The following is a description of a gene set: Down-regulated genes in pediatric adrenocortical tumors (ACT) compared to the normal tissue. Pediatric adrenocortical tumors (ACT) are rare and often fatal malignancies; little is known regarding their etiology and biology. To provide additional insight into the nature of ACT, we determined the gene expression profiles of 24 pediatric tumors (five adenomas, 18 carcinomas, and one undetermined) and seven normal adrenal glands. Distinct patterns of gene expression, validated by quantitative real-time PCR and Western blot analysis, were identified that distinguish normal adrenal cortex from tumor. Differences in gene expression were also identified between adrenocortical adenomas and carcinomas. In addition, pediatric adrenocortical carcinomas were found to share similar patterns of gene expression when compared with those published for adult ACT. This study represents the first microarray analysis of childhood ACT. Our findings lay the groundwork for establishing gene expression profiles that may aid in the diagnosis and prognosis of pediatric ACT, and in the identification of signaling pathways that contribute to this disease. from publication West AN, Neale GA, Pounds S, Figueredo BC, Rodriguez Galindo C, Pianovski MA, Oliveira Filho AG, Malkin D, Lalli E, Ribeiro R, Zambetti GP (PMID 17234769) Human Gene Set: WEST_ADRENOCORTICAL_TUMOR_DN species: Homo sapiens, and this is the list of marker genes: SGCG, MT1G, GPC3, CREM, GABBR1, RAI2, PDK2, CXCL12, DDX5, FZD1, FMO2, PATZ1, ABCG1, MAN2B1, LRP1, EXT1, CHD3, NUP88, MINAR1, RHOT1, RARRES2, MGP, DUSP1, TNFSF13, POLDIP2, RPL23, AAK1, CEP68, FTSJ1, HDDC2 (NCBI Gene Id 51020), KCNK3, EMILIN1, CDC42EP4 (NCBI Gene Id 91740), ATP2B3, LY6E, ADAMTSL3, FAAH, HGF, C3, POSTN, AOX1, IL18BP, VWA5A, MEIS3P1, RSC1A1, CBFA2T3, GEM, RBFA, OLFML1, MICALL2, C1R, AMPD3, PLXNB3, RBMS3, GPT, SERPING1, DLGAP1, CYP11B1, HTR2B, PTH1R, HSD3BP1, DHRS1, HOXA5, LHPP (phospholysine phosphohistidine inorganic pyrophosphate phosphatase), DIP2C, GRAMD4, FAS, KCNA5, FOS, SPOCK2, VPS51, KCNA4, SEPTIN4, SV2B, MYO7A, TPSAB1, PCGF2, FKBP9, SORBS2, EHD3, VCAN, SPSB3, DUSP26, AADAC, RGN, SLCO2A1, CTDSP1, CCL2, SPON1 (NCBI Gene Id 84806), GSTT1, IRF1, TALDO1, CYP2A6, KLF5, PLN, WFDC1, PSEN2, SGSM2, JUNB, ASMTL, OGT, HOXB1, COL6A1, TMCC1, SF1, ARHGEF15, VSNL1, SORBS1, CD55, VIPR1, INTS9, MPST, CTH, LAMC3, MID2, LSP1, SEMA6A, WDR6, RPS4X, CYP21A2, TSPO, LSM14A, CD81, CDH6 (NCBI Gene Id 1004), FBXW4, RASIP1, SMTN, NUDT3, NR2F2, PID1, FRRS1L, CYP11B2 (NCBI Gene Id 1585), MT1X, AEBP1, MAFF, CTAGE9, ALAS1, MYLIP, CERK (NCBI Gene Id 64781), GMPR, PLTP, ARL17A, CSF1, CASP9, TGFB3, SOD3, KLF11 (KLF transcription factor 11), HOXB5, CTTN, IL33, SHLD2, EGR3, PDGFRA, RARA, THUMPD1, FLVCR2, KCNN2, IER3, CNN2, CYBB, CREB3L1, GPM6B, SSPN, ADIPOQ, VAMP2, HEPH, PPIG, NRXN1, STAB1 (stabilin 1), WNT4, KCNJ5, CHRDL1 (NCBI Gene Id 91851), LMF1, ST3GAL6, GPRASP1, MMP2, SLC25A28, PORCN, COX16, RUNX1, OXR1, HSD3B2, COX7A1, IRF4, PHKG1, GAS1, WBP1L, PODXL, ITGA8, KIF5C, CER1, RCBTB2, MAOB, LYRM1, CUL5, EPN3, OMD (NCBI Gene Id 4958), ACSM5, DKK3, CALHM2, CXCR5, RBPMS, EIF3M, FHL1, EIF2D, TOB1, CAT, PLA2G6, CLEC3B, EIF4A1, OGN, KYNU, AHNAK, DNAJC12, SIRT2, SCUBE2, PAWR, ATP10A, APOL6, TMEM222, ACTG1, CTSO, PRPF8, RAMP1, GGT5, EIF4EBP3, PARP3, MSRA, ZYX, DXO, EEF1D, BGN, AKR1B1 (aldo-keto reductase family 1 member B), MT1H, LTBP4, SLC25A4, ALDH6A1, CEBPD, CTSF, LRRN3, MUC2, ZNF185, NDUFB11, LAMA2, POLL, C1S, MICALL1, SPATA20 (NCBI Gene Id 64847), FXYD1, AMT, APOC1, MT1E, DPT, REM1 (NCBI Gene Id 28954), RPL23A, ABHD14A, STUB1, CSDC2, VTN, LRP5, ATRX (ATRX chromatin remodeler), RAB13, ACADVL, NR2F1, SCN7A, RPL29P5, LARP6, C1QTNF1, BCAT2, SIRPA, NKRF, ROBO3, UBB, USP47, G0S2, ADAM22, TPD52L1, UBXN1, MFAP5, CREBL2, SRGAP3, MECP2, KMT2A, COL4A4, FOSB, CDH2, CIB2, MOXD1, PDGFD, INPP5K, SEMA3B, MEPCE, CCDC85B, TCF21, CLUAP1, PGPEP1, TEK, PKIG (cAMP-dependent protein kinase inhibitor gamma), PHACTR2, CD34, GTF2H5, ARHGEF3, HOPX, NGFR (nerve growth factor receptor), HIBCH, ATP1B3, TNFSF10, LPAR1, H3-3B, TK2, IFITM3P7, SUPT6H, C7, KLHDC8A, DEFB4A, COLEC11, PLEKHO1, SPON2, EIF2B4, RPL5, AOC4P, PCSK2, FBLN1, JAM3, MS4A2, NR4A2, FGF12, EOLA1, LUZP2, AKR7A2, BTG2, CCNL1, NDRG2, EIF3L, MPG, NYNRIN, ALDH3A2, IFITM2, RPL39, ZNF688, ZMYND11, CAMK1, GLS2, GLUD1 (NCBI Gene Id 2746), IRF5, FLRT1 (NCBI Gene Id 23769), FAXDC2, TTC19, ARAP1, CNP, RASSF2, DGKA, HDAC4, IGFBP5, BAALC, IGFBP6, PIP4K2B, IL17RB, DOCK1, TM4SF1, LUC7L, RER1, ATP1A2, EMD, RIMS2, ASB13, ARHGAP25, TMEM204, ZFP36L2 (ZFP36 ring finger protein like 2), TNNI3K, RSF1, MICAL2, CYP7B1, RAPGEF4, ECHDC2, CFD, ESRRG, VEZF1, EGR1, IFT46, GAS7 (NCBI Gene Id 8522), FERMT1, FUT8, ACSF2, IER2, FAH, BDH2, NBL1, KAT6B, TOB2, LUM, EPHA2, PTGER4, NAB2, OR2J3, PTCH1, GCAT, PLEKHO2, NUPR1, MMP23B, RPS9, DNAJB12, SOX9, KAT2A, TNFRSF25, MGMT, FOXC2, TAGLN, CASKIN2, DNPH1, CRHBP, KLF6, EFEMP2, ALDH1L1, CNOT1, IFI35, CNNM2 (NCBI Gene Id 54805), MTNR1A, GBX1, MXRA5, RNF122, SFRP4, PLPP3, SLC23A2, CSRP1, PLAT, MXD4, ID4, PCDHGC3, NPR1, SIRT1, OLFML3 (olfactomedin like 3), TNS1 (tensin 1), PLP1 (NCBI Gene Id 5354), NOCT, LEPR, FAM53B, ITM2A, TLE2, ASCC1, CAVIN1, OPLAH, PARVB, CCN3, RORA, ICAM1 (intercellular adhesion molecule 1), NPEPPS, MAP3K11, PDZRN3, LHFPL6 (LHFPL tetraspan subfamily member 6), DYNLT3, PLD1, ST3GAL4, ASPN, SLC47A1, ISLR, PRELP, KLF2, MYLK, FTSJ3, RBKS, DNAJC4 (NCBI Gene Id 93087), SEPTIN6, LGI1, FBLN5, NHERF1, SREBF1, ERBB3, SLC16A2, H2BC15, HYI, B3GNT4, ABCB1, SORBS3, CALD1 (caldesmon 1), KDM5A, AGTR1, NAA60, UBTF, CFH, PAK5, PEBP1, MVP, SRSF5, ARMC9, RPL38, ZFP36, ADH1B, LAMB2, CHD4, EPHX2, SYDE1, RPL27, AXL, LRRC32, TSPYL4 (TSPY like 4), GSDMD, DCXR, NEIL1, MT2A, CD302, DDX27, HSD3BP2, KCNQ1, EPX, WWP2 (WW domain containing E3 ubiquitin protein ligase 2), TPT1, CRISPLD2, RHOB, HNF4A, COL4A3, CUEDC2, CD2BP2, NPY1R, IGFBP4, METTL9, NR4A1, APOD, TCF7L1, ESR1, ZNF331, PTGIS, KLK5, CD248, MEIS2, KCTD14, NFIC, EEF1A1, SHC2, RPL29, CYB561, NAP1L1, PLA2G4A, NCF4, PNLIPRP1, NR4A3, PARVA, DCN (NCBI Gene Id 1634), RARRES1, PTPN4, RNF39, LMOD1 (leiomodin 1), ABLIM1, CRYL1, SSH3